The following is a description of a gene set: Abnormal basophil morphology Human Gene Set: HP_ABNORMAL_BASOPHIL_MORPHOLOGY species: Homo sapiens Any structural abnormality or abnormal count of basophils., and this is the list of marker genes: RUNX1, SRSF2, BCR, BACH2, TET2 (tet methylcytosine dioxygenase 2), ASXL1, ABL1, KIT